The following is a description of a gene set: species: Homo sapiens Human Gene Set: chr21q22, and this is the list of marker genes: IGSF5, KRTAP13-4, RPS5P2, ERG, RRP1, TRAPPC10, LINC00945, C2CD2, URB1-AS1, RIMKLBP1 (NCBI Gene Id 54031), LINC00310, KRTAP26-1, EPCIP, DSCR8, SON, KRTAP19-9P, YBEY, HEPFAL, ENSG00000207147, ENSG00000207503, KRTAP12-5P, MX1-AS1, KRTAP10-9, LINC01548 (long intergenic non-protein coding RNA 1548), ENSG00000232124, SLC5A3, MRAP-AS1, TFF2, PKNOX1, LRRC3-DT, EZH2P1, RNU6-696P, KRTAP22-1, PAXBP1, ETS2-AS1, SPATC1L, SLX9, PICSAR, ETS2, USF1P1 (upstream transcription factor 1 pseudogene 1), KRTAP20-2, ENSG00000303490, PCNT, SNORA80A, KRTAP10-3, KRTAP12-1, RUNX1, KCNJ6-AS1, PAXBP1-AS1, DSCR10, ENSG00000225555, KRTAP10-1, RIPK4, HUNK, RNA5SP491, LINC01426, KCNJ6, MIR6815, CLDN14, KRTAP10-2, OLIG1, RPS26P4, ATP5MFP1, LINC00114, PFKL, ICOSLG, ENSG00000286224, WDR4, COL6A2-DT, ERVH48-1, CHAF1B, DSCAM-AS1 (NCBI Gene Id 100506492), KRTAP8-3P, KRTAP20-3, SNRPGP13, DSTNP1, PSMD4P1, JCADP1, HLCS, LINC01424 (long intergenic non-protein coding RNA 1424), KRTAP21-2, COL18A1-AS1, LINC00479 (NCBI Gene Id 150135), IFNAR1, KRTAP23-1, CFAP410, MEMO1P1, LINC01671, KRTAP8-2P, PWP2, RPL8P2, ENSG00000238390, UBASH3A, MTRES1P2, COL6A2 (collagen type VI alpha 2 chain), LINC00319, HLCS-AS1, LINC02940, COL18A1-AS2, KRTAP24-1, TTC3-AS1, LINC00323, MIR5692B, GET1-SH3BGR (GET1-SH3BGR readthrough), UBE3AP2 (ubiquitin protein ligase E3A pseudogene 2), TCP10L, KRTAP19-4, SNORA70, RPL23AP12, CLIC6, LINC00322, MTND5P1 (MT-ND5 pseudogene 1), B3GALT5, LINC00316, KRTAP15-1, MIR4760, MRAP (melanocortin 2 receptor accessory protein), PRMT2 (protein arginine methyltransferase 2), RNA5SP492, URB1, LSS, LINC01436, PRDM15, LINC01679, EXOSC3P1, KRTAP25-1, IMMTP1, KRTAP6-1, LINC01547, HSF2BP, GART, BRWD1-AS1, KRTAP10-11, KRTAP10-6, LINC01700, ENSG00000232360, KRTAP19-7, LINC00112, MIS18A, TIAM1, IL10RB, RPL18AP2, MX1, COL18A1, FTCD, CBR3, LINC01423, LNCTSI, MIR6070, PSMA6P3, POFUT2, TFF1, DONSON, NDUFV3, IL10RB-DT, KRTAP6-3, PTTG1IP, LINC02943, RNF6P1, ENSG00000264452, SIM2, TMPRSS3, ITSN1, LRRC3, DSCAM-IT1, TSPEAR-AS1, PSMG1, KRTAP11-1, SH3BGR, ZBTB21, H2BC12L, RPL31P1, SLC19A1, EPCIP-AS1, LINC01690, PDE9A-AS1, TFF3, ENSG00000231324, FBXW11P1, RPL23AP3, S100B, HMGN1, ADARB1, KRTAP20-4, ENSG00000233393, RPL34P3, MRPL51P2, KRTAP12-4, DIP2A, KRTAP10-4, RPS20P1, MRPL20P1, IFNGR2, MIR3197, MIS18A-AS1 (NCBI Gene Id 100874202), BACE2, LINC00313, UMODL1-AS1, RSPH1-DT, KRTAP19-2, SSR4P1, LINC00165, PCP4, CSTB, KRTAP10-7, HUNK-AS1, PDXK, RCAN1, SOD1, GATD3, BRWD1-IT1, ATP5PO, TMEM50B (transmembrane protein 50B), DNMT3L, RNU6-992P, DNMT3L-AS1, PIGP, SLC37A1, IFNAR2, MCM3AP-AS1, PCSEAT, AIRE, KRTAP21-4P, ITGB2-AS1 (ITGB2 antisense RNA 1), RIPPLY3, DPRXP5 (NCBI Gene Id 503646), KRTAP19-11P, KRTAP13-5P, SUMO3 (NCBI Gene Id 6612), ENSG00000274248, KRTAP20-1, LINC01694, EVA1C, LINC00205, TMEM97P1, KCNE1, BACE2-IT1, HMGN1P2, VPS26C, KRTAP6-2, SMIM34, KRTAP7-1, RSPH1, OLIG2, LCA5L, TIAM1-AS1, BNAT1, KRTAP19-1, KRTAP10-13P, FRGCA, U2AF1, KRTAP19-5 (keratin associated protein 19-5), LINC00307, UMODL1, GET1, SRSF9P1, MTCO1P3, KRTAP19-3, CBR3-AS1, LINC00163, IFNAR2-IL10RB, SMIM11, RNU6-1150P, TIMM9P2, KRTAP13-3, MIR6508, MYL6P2, TRPM2, TTC3, KRTAP13-2, CFAP298, AGPAT3, DOP1B, TRPM2-AS, PCBP3-AS1, KRTAP12-3 (keratin associated protein 12-3), KRTAP22-2, SIK1, RPS9P1, KRTAP19-8, METTL21AP1, KRTAP10-12, ENSG00000221398 (NCBI Gene Id 124900475), CBS, RNU6-1149P, MIR6814, DNAJC28, LINC00315, TMPRSS2, LINC00334, KRTAP8-1, KRTAP13-6P, RRP1B, TSPEAR, SPATA20P1, OR7E23P, RNU6-859P, CRYAA, FTCD-AS1, MYL6P1, RPS5P3, PCBP3, RPL3P1, PLAC4, PCBP2P1, LINC02575, SOD1-DT, C21orf140, UBE2G2, KRTAP13-1, KRTAP21-1, MCM3AP, ZNF295-AS1, ABCG1, ENSG00000266692, COL6A1, LINC00111, SETD4-AS1, TPT1P1, MIR6501, SCAF4 (SR-related CTD associated factor 4), KRTAP19-10P, RPL23AP4 (NCBI Gene Id 54029), RN7SL678P, HLCS-IT1, KRTAP27-1, PDE9A, KRTAP10-10, MRPS6, RNA5SP490, MIR802, KRTAP10-8, MIR4327, KCNE2, KRTAP19-6, MTCYBP21, B3GALT5-AS1, KRTAP12-2, BTF3P6, CRYZL1, DSCR9, SYNJ1, LINC01668, LINC00159, SNORA62, KCNJ15, YRDCP3, LINC01678, DIP2A-IT1, CBR1-AS1, PPP1R2P2, CFAP298-TCP10L (NCBI Gene Id 110091775), LINC00649, MORC3, DSCAM, ENSG00000287082, RN7SL740P, ITGB2, AATBC, KRTAP10-5, KRTAP21-3, H2AZP1, MTND6P21, RPSAP64, LINC00160, SETD4, C21orf58, DSCR4-IT1, MX2, RUNX1-AS1, CLDN8, DYRK1A, CBR1, BRWD1, FAM3B, ENSG00000287470, ENSG00000295465, DSCR4, RNU6-396P